The following is a description of a gene set: Reactome Pathway: Maturation of protein M_9694594 part of: Translation of Structural Proteins This COVID-19 pathway has been created by a combination of computational inference from SARS-CoV-1 data (https://reactome.org/documentation/inferred-events) and manual curation, as described in the summation for the overall SARS-CoV-2 infection pathway.<br><br>Protein M, part of which is N-glycosylated, accumulates in the Golgi complex and recruits Spike protein to the sites of virus assembly and budding in the ERGIC species: Homo sapiens, and this is the list of marker genes: M